The following is a description of a gene set: species: Homo sapiens Any process that stops, prevents, or reduces the frequency, rate or extent of the breakdown of a protein or peptide by hydrolysis of its peptide bonds, initiated by the covalent attachment of ubiquitin, and mediated by the proteasome. Human Gene Set: GOBP_NEGATIVE_REGULATION_OF_PROTEASOMAL_UBIQUITIN_DEPENDENT_PROTEIN_CATABOLIC_PROCESS, and this is the list of marker genes: HFE, USP38, CCAR2, CSNK2A1, UCHL5, MTM1 (NCBI Gene Id 4534), PANO1, ARHGAP5-AS1, HSP90AB1, BAG5, PBK, RYBP, RPL11, CSNK2B, STYX, MAP1A, FHIT, PHF20L1, KLHL40, N4BP1, GIPC1, DDRGK1, USP9X, USP26, TRIM39, WAC, TTC36 (NCBI Gene Id 143941), SHH (NCBI Gene Id 6469), UBXN1, USP7, CSNK2A2, CAMLG, TAF9 (NCBI Gene Id 6880), TLK2, USP5, SMARCC1, NOP53, OGT, SENP1, EIF3H, PARK7, BAG6, PABPN1L